Given this list of marker genes Ttll11, Ttll7, Ttll5, Ttll4, Ttll6, here is a description of the gene set: Catalytic reaction: ATP + L-glutamate + L-glutamyl- = ADP + H+ + L-gamma-glutamyl-L-glutamyl- + phosphate. species: Mus musculus Mouse Gene Set: GOMF_PROTEIN_GLUTAMIC_ACID_LIGASE_ACTIVITY_INITIATING